Given this list of marker genes RHOV, APOA1, HP, ARSK, CCDC80, CD36, MTTP, FCGRT, RBM45, RBP4, HAO2, CCDC74B, SUCNR1, CLEC2D, PC, SMYD1, FABP1, CFI, POU4F1, CHST1, TMEM87A, CIT, CYP2E1, BST1, LEP, SOCS3, ZKSCAN1, VNN1, APOA4, CA3, SLC36A2, GSDMC, SLC5A12, PLIN1, LPL, DGAT2, GZMB, PTGER3, KIF3B, THRSP, WDFY1, BLOC1S6, NPC1L1, THA1P, ISG15, PDZK1, HBB, WFIKKN2, ADIPOQ, LTK, FBXO41, IFIT1B, GGT1, UPK1B, SERPINA10, FABP4, EXOSC10, HBA2, C1QTNF1, HSPA12A, CFD, NPR3, NEUROD2, ACAA1, DHH, KRAS, AMY2B, TRIM15, EXD1, SCD, CIDEC, SAA1, CST6, RETNLB, KRT12, FAM241A, FAM3B, PLIN4, ETNPPL, KCTD14, APOC2, PLEKHM1, SELENOS, XIST, TMEM116 (NCBI Gene Id 92920), FUZ, AKR1B10, PCDH17, CD163, INMT, SASH3, SSR1, AP1M1, TF, FMN2, ADIG, LHFPL2, TMIE, CHAC1, KIAA1671, RSAD2, ALPI, THPO, here is a description of the gene set: Genes up-regulated in Paneth cell (part of intestiinal epithelium) of mice with hypomorphic (reduced function) form of ATG16L1. from publication Cadwell K, Liu JY, Brown SL, Miyoshi H, Loh J, Lennerz JK, Kishi C, Kc W, Carrero JA, Hunt S, Stone CD, Brunt EM, Xavier RJ, Sleckman BP, Li E, Mizushima N, Stappenbeck TS, Virgin HW 4th (PMID 18849966) species: Mus musculus Human Gene Set: CADWELL_ATG16L1_TARGETS_UP Susceptibility to Crohn's disease, a complex inflammatory disease involving the small intestine, is controlled by over 30 loci. One Crohn's disease risk allele is in ATG16L1, a gene homologous to the essential yeast autophagy gene ATG16 (ref. 2). It is not known how ATG16L1 or autophagy contributes to intestinal biology or Crohn's disease pathogenesis. To address these questions, we generated and characterized mice that are hypomorphic for ATG16L1 protein expression, and validated conclusions on the basis of studies in these mice by analysing intestinal tissues that we collected from Crohn's disease patients carrying the Crohn's disease risk allele of ATG16L1. Here we show that ATG16L1 is a bona fide autophagy protein. Within the ileal epithelium, both ATG16L1 and a second essential autophagy protein ATG5 are selectively important for the biology of the Paneth cell, a specialized epithelial cell that functions in part by secretion of granule contents containing antimicrobial peptides and other proteins that alter the intestinal environment. ATG16L1- and ATG5-deficient Paneth cells exhibited notable abnormalities in the granule exocytosis pathway. In addition, transcriptional analysis revealed an unexpected gain of function specific to ATG16L1-deficient Paneth cells including increased expression of genes involved in peroxisome proliferator-activated receptor (PPAR) signalling and lipid metabolism, of acute phase reactants and of two adipocytokines, leptin and adiponectin, known to directly influence intestinal injury responses. Importantly, Crohn's disease patients homozygous for the ATG16L1 Crohn's disease risk allele displayed Paneth cell granule abnormalities similar to those observed in autophagy-protein-deficient mice and expressed increased levels of leptin protein. Thus, ATG16L1, and probably the process of autophagy, have a role within the intestinal epithelium of mice and Crohn's disease patients by selective effects on the cell biology and specialized regulatory properties of Paneth cells.